The following is a description of a gene set: species: Mus musculus Mouse Gene Set: GOCC_INTERCALATED_DISC A complex cell-cell junction at which myofibrils terminate in cardiomyocytes; mediates mechanical and electrochemical integration between individual cardiomyocytes. The intercalated disc contains regions of tight mechanical attachment (fasciae adherentes and desmosomes) and electrical coupling (gap junctions) between adjacent cells., and this is the list of marker genes: Rangrf, Myh1, Ankrd23, Cdh2, Hamp, Itgb1, Hamp2, Pik3ca, Scn4b, Tjp1, Pgm5, Cxadr, Sptbn4, Ank3, Ptk2, Prkca, Slc8a1, Gja1, Ank2, Adra1b, Slc2a1, Nrap, Gja5, Fxyd1, Actn1, Atp1b1, Jup, Dsp, Atp1a2, Des, Ctnnb1, Dst, Atp1a1, Sptan1, Scn1a, Scn1b, Xirp1, Gja6, Pkp2, Scn5a, Ctnna3, Slc4a1, Dsc2, Scn2a, Obscn, Fgf13, Slc31a1, Kcnj11, Tln2, Akap6, Vcl, Atp2a2, Slc9a1, Ywhah, Anxa6, Gm1123, Ctnna1, Anxa5, Tmem65, Pak1 (p21 (RAC1) activated kinase 1), Camk2d, Kcna5, Vamp5, Fhod1, Kcnj2, Dsg2, Cav3